The following is a description of a gene set: Mechanical ventilation (MV) with tidal volumes of 10-12 ml/kg is considered safe in the absence of acute lung injury (ALI). However, recent studies show that, when lung injury is already present, tidal volumes of this magnitude increase inflammation and injury in the lungs. We hypothesized that MV with tidal volumes of 10-ml/kg can also function as a cofactor in the initiation of ALI by modulating the transcriptional response to bacterial products. To test this hypothesis, we developed a mouse model in which MV did not independently cause inflammation or injury but augmented the inflammatory response to low-dose aspirated LPS and promoted development of ALI. We analyzed gene expression in lungs from 24 mice assigned to four different groups: control, MV only, intratracheal LPS only, and MV + LPS. There were twice as many differentially regulated genes in the MV + LPS group compared with the LPS-only group and 10 times as many differentially regulated genes compared with the MV-only group. For genes up-regulated by LPS treatment alone, the addition of MV further augmented expression. Cytokine concentrations in bronchoalveolar lavage fluid and tissue distribution of an intracellular protein, GADD45-gamma, correlated with mRNA levels. We conclude that MV with conventional tidal volumes enhanced the transcriptional response to LPS and promoted development of ALI. species: Mus musculus from publication Altemeier WA, Matute-Bello G, Gharib SA, Glenny RW, Martin TR, Liles WC (PMID 16116230) Genes up-regulated in lung tissue upon LPS aspiration with mechanical ventilation (MV) compared to control (PBS aspiration without MV). Human Gene Set: ALTEMEIER_RESPONSE_TO_LPS_WITH_MECHANICAL_VENTILATION, and this is the list of marker genes: TREX1, GPR84, TFPI2, CLEC4D, LILRB1, SAP30, NFKBIZ, CSF2, PFKFB3, GEM, USP18, ITGAM, MT1F, CLEC4E, CCL2, MARCKSL1, TNFAIP2, MXD1 (MAX dimerization protein 1), TNFSF9 (NCBI Gene Id 8744), TFEC, IFIH1, SLC15A3, SELL, FCER1G, ST3GAL1, OAS3, MEFV, CD14, IL1RN, SELP, IL36G, FPR2, F13A1, HCAR2, GPR65, ISG15, IRF7, CCL20, CCR2, RCAN1, RELB, FCGR2A, CTPS1, CCRL2, PLAUR, GK, CXCL2, SLC26A4, IL15, GADD45G, SOCS3, CCR1, GCH1, GBP2, CSF2RB, NFKBIA, SERPINE1, BCL3, IL4I1, TIFA, CCL15, SOD2, ATF3, TGM1, RAB20, MAFF, IL1A (interleukin 1 alpha), CMPK2, F3, ARG2, CCL4 (C-C motif chemokine ligand 4), SLFN12, IL1R2, TRIM5, CYBB, GDA, BST1, BCL2A1, CSF3R, ADM, ADAMTS4, VCAN, TLR2, C5AR1, TNFAIP3, IL1B, JUNB, LCP2, LST1, SLA, IFIT2 (NCBI Gene Id 8375), THBS1, LITAF, PLA2G7, CASP4, CXCL10, OASL2P, PLEK, CLEC6A, NFIL3, STAT1, IRGM, CCL17, HPX, CH25H, CEBPD, RDH5, OAS2, CCL3, AKAP12, IFIT1B, MAP3K8 (NCBI Gene Id 8040), TIMP1, IL6, UPP1, MS4A6A, MT1X, STAT2 (NCBI Gene Id 6773), OSMR, CXCL6, EBI3, FCGR1A, FGL2